The following is a description of a gene set: Reactome Pathway: Progressive trimming of alpha-1,2-linked mannose residues from Man9/8/7GlcNAc2 to produce Man5GlcNAc2 species: Homo sapiens part of: N-glycan trimming and elongation in the cis-Golgi In the cis-Golgi, Man7, Man8 or Man9 N-glycans are progressively trimmed to Man5 N-glycans. The reaction can be catalyzed by one of three known mannosidases, expressed in different tissues and with slightly different affinity. These enzymes trim the mannoses in a different order, but produce the same output with 5 mannoses.<br>A small confusion on the nomenclature of these genes coding for these enzymes is present in the literature: the standard HGNC symbols are MAN1A1, MAN1A2, MAN1C1, but MAN1A2 is also referred to as MAN1B in certain publications, while MAN1B1 is the enzyme acting in the ERQC compartment on unfolded glycoproteins. Moreover, the names do not correspond to a preference of these enzymes for which of the three mannose branches these trim first., and this is the list of marker genes: MAN1C1, MAN1A1, MAN1A2